The following is a description of a gene set: Human Gene Set: GOBP_NEGATIVE_REGULATION_OF_NUCLEAR_TRANSCRIBED_MRNA_CATABOLIC_PROCESS_DEADENYLATION_DEPENDENT_DECAY Any process that stops, prevents or reduces the frequency, rate or extent of nuclear-transcribed mRNA catabolic process, deadenylation-dependent decay. species: Homo sapiens, and this is the list of marker genes: HNRNPU, TENT4A (terminal nucleotidyltransferase 4A), HNRNPD, IGF2BP1, SYNCRIP, TOB1, PAIP1, DHX9, PABPC1, CSDE1, TENT4B, YBX1 (Y-box binding protein 1)